The following is a description of a gene set: The ability of dendritic cells (DCs) to activate immunity is linked to their maturation status. In prior studies we have shown that selective antibody-mediated blockade of inhibitory FcgRIIB receptor on human DCs in the presence of activating immunoglobulin (Ig) ligands leads to DC maturation and enhanced immunity to antibody-coated tumor cells. Here we show that Fcg receptor (FcgR) mediated activation of human monocytes and monocyte-derived DCs is associated with a distinct gene expression pattern, including several inflammation associated chemokines as well as type 1 interferon (IFN) response genes including the activation of signal transducer and activator of transcription 1 (STAT1). Human Gene Set: GSE7509_FCGRIIB_VS_TNFA_IL1B_IL6_PGE_STIM_DC_DN species: Homo sapiens Genes down-regulated in dendritic cells: anti-FcgRIIB versus inflammatory cytokine cocktail. from publication Dhodapkar KM, Banerjee D, Connolly J, Kukreja A, Matayeva E, Veri MC, Ravetch JV, Steinman RM, Dhodapkar MV (PMID 17502666), and this is the list of marker genes: ADAMTS10, EPS15L1, SLC25A37, KCNS3, UIMC1, VAMP2, MTHFSD, CLK2, APPL2, MALAT1, EWSR1, LUC7L2, SECISBP2, PHF21B, CEP135, DISC1, MIRLET7I (microRNA let-7i), SCUBE1, ARRDC2, SCARNA17, TRIO, HOXB6 (NCBI Gene Id 3216), BEND4, ARHGEF1, TLE2, CC2D1B, CNTRL, RCCD1, CDH24, SNPH, AKAP8L, CEP250, ARID4A, CASS4, BAZ2B, CCHCR1, NUDT13, LBX1, SHISA2, GABBR1, SNX29, SYNGAP1, KMT5C (NCBI Gene Id 84787), MYOZ3, CROCC, NSMF, TIAM1, NHLRC1, KRTAP17-1, MBD6, MYO15A, MEGF11, IQCF1, DTX3, MIR34B, ANKS3, BRPF1, IFFO1, BVES, SET, ANKRD24, NRBP2, CIZ1, HOXA4, NPFF, WHAMM, HOOK3, BRD8, MYMK, CCDC157, PVT1, CNTNAP1, ENTREP3, GRAMD1A, LMBR1L, TENT5C, IGFLR1, XIST, WNT4, CCNL2, DENND6B, AKAP5, DOCK6, MIR346, CARS2, PNPLA6, ABCD4, SCARF2, DST, FNBP4, ZNF276, MICAL3, CCDC85C, KRBA1 (NCBI Gene Id 84626), LUC7L, PICK1, SYNE2, GLT1D1 (glycosyltransferase 1 domain containing 1), SNAPC4, CLCN2, IFNL2, DCLK2, DZIP1L, SFTPA1, CEP295NL, GOLGA1, DGKZ, MIR155, REXO1, WHRN, LRRC45, MIR139 (microRNA 139), UTRN, PLD2, PANK4, PRSS33, PLEKHA7, MT3, FAM133B, PPP1R9A, GTPBP6, LENG8 (NCBI Gene Id 79162), AIRE (autoimmune regulator), SCARNA13, SFTPC, ZMYND11, STAB2, USP17L5, MINK1, MIR150, PLEKHG5, ARFGAP1, CORO6, TGFA, NSG2, CTRC, RAPGEF3, GDPD3, GARIN1B, LUC7L3, PARP6, TANC2, LHX8, ADAMTSL5, MAGEF1, ANKRD11, ALAS2 (NCBI Gene Id 90735), FAM193B, SCARF1, SYN3, SNORD73B, TCEA2, PPP1R12B, RBM33